Given this list of marker genes STRBP, TLR8, STAU2, RC3H2, YRDC, NLRP6, ZBP1, AGO1, ILF2, AGO4, HSPD1, OAS3, ADAR, MRPL44, CLTC, MYH4, EIF4A1, ILF3, SIDT2, ADAD1, MSN, ELAVL1, OASL, RC3H1, DUS2, ACTN1, LSM14A, LRRFIP1, SLC3A2, TARBP2, EIF4H (eukaryotic translation initiation factor 4H), DDX60L, DHX9, APTX, DICER1, MTDH, NLRP1, TUBA1B, OAS1, IFIH1, DHX36 (NCBI Gene Id 96337), ZNF346, TLR3, DHX30, DHX33, ADAD2, OAS2, HMGB1 (NCBI Gene Id 3146), ADARB2, STK19, EIF4B, TFRC, DDX1, PRKRA, DDX21, SIDT1, STAU1, A1CF, AGO2, RIGI, HNRNPU, DGCR8, RFTN1, DDX60, TLR7, DHX15, HSP90AB1, SUPV3L1, TUBB4B, ZFR (NCBI Gene Id 51663), ZFR2, EIF2AK2, MBNL1, ADARB1, PRKRIP1, AGO3, VIM, DHX58, here is a description of the gene set: Human Gene Set: GOMF_DOUBLE_STRANDED_RNA_BINDING studied in species Homo sapiens Binding to double-stranded RNA.